Given this list of marker genes Aopep, Metap2, Dpp8, Xpnpep2, Dpp9, Metap1d, Lap3, Rnpepl1, Metap1, Ctsl, Rnpep, Kdm8, Jmjd7 (NCBI Gene Id 433466), Xpnpep3, Npepps, Xpnpep1, Dpp3, Dpp7, Naaladl1, Lta4h, Mmp14, Pepd, Actmap, Dpp4, Anpep, Trhde, Enpep, Blmh, Ctsh, Mmp16, Tpp2, Lnpep, Erap1, F11, Dnpep, Npepl1, here is a description of the gene set: Mouse Gene Set: GOMF_AMINOPEPTIDASE_ACTIVITY Catalysis of the hydrolysis of a single N-terminal amino acid residue from a polypeptide chain. studied in species Mus musculus